Given this list of marker genes PRKN, FCGR2B, TMBIM6, APP, HYOU1, here is a description of the gene set: studied in species Homo sapiens Human Gene Set: GOBP_NEURON_INTRINSIC_APOPTOTIC_SIGNALING_PATHWAY_IN_RESPONSE_TO_ENDOPLASMIC_RETICULUM_STRESS The series of molecular signals in which an intracellular signal is conveyed to trigger the apoptotic death of a neuron. The pathway is induced in response to a stimulus indicating endoplasmic reticulum (ER) stress, and ends when the execution phase of apoptosis is triggered. ER stress usually results from the accumulation of unfolded or misfolded proteins in the ER lumen.